The following is a description of a gene set: Pain in muscle. Myalgia Human Gene Set: HP_MYALGIA species: Homo sapiens, and this is the list of marker genes: PMP22, HLA-DPA1, SCN4A, MTTP, ALMS1, COX6B1, TNFRSF1A, NLRP3, MLX, IL12A, CTNNB1, ANK1, DSE, LRP12, DMD, TBX1, POLG2, MT-TK, LMNA, HLA-DRB1, ACP5, SLC25A4, SCN9A, LBR, APC, P4HA2, DNM1L, POLG, OBSCN, NOD2, DNM2, GPR101, IL2RB, TET2, HNRNPA1, RREB1 (NCBI Gene Id 6239), ANKRD55, NLRP12, ANO5, FKTN, POMT1, SDHA, MTMR14, ACADM, HLA-DPB1, LPIN1, PRDM5, TRAPPC11, PHKG1, CLCN1, RNASEH1, MOCOS, VCP, TWNK, ALDOA, MPV17, FKRP, TMEM126B, MATR3, BIN1, PDGFRA, DGUOK, GK, STAT4, SPTB, MT-CO1, CD247, HLA-B, PHKA1, HADHA, PGAM2, IL12B, IFNGR1, MRPS2, IL23R, JMJD1C, COMT, TK2, PTPN22, PTPN6, CHCHD10, UBAC2, LDHA, PHKB, NLRC4, GP1BB, CR2, SPTA1, DNA2, IL12A-AS1, PLAAT3, DNAL4, RYR1, EPB42 (NCBI Gene Id 2038), DNASE1L3, MSTO1, PTPN2, SLC4A1, ORAI1, ENO3, CAPN3, TLR4, ATP2A1, PHKG2, FAS, IL10, SLC12A3, RAD51, FILIP1, ERAP1, PPARG, MEFV, MIEF2, PNPLA2, ADA2, FDX2, STIM1, IL2RA (NCBI Gene Id 3559), CAV3, PHKA2, KIT, OPA1, SVIL, FLNC, PFKM, CRPPA, EXT2, CLCNKB, TPM2, KLRC4, MLIP (muscular LMNA interacting protein), ASXL1 (NCBI Gene Id 23393), GLA, BVES, ZNF469, KY, UFD1, PRTN3, RRM2B, OTULIN, HADHB, ACAD9, DYSF, TNXB, DNAJB6, ARVCF, FMR1, NTN1, HPDL, MYOT, LPIN2, CASQ1, AMPD3, MDM4, PYGM, POLR3A, HSPG2, MT-CO3, SEC24C, RBCK1, C4A, IRF4, DCC, AIP, HIRA, ALDH4A1, VWA1, HMGCR, PRORP, MVK, CPT2, CCDC78, AMPD1, CTLA4, MYF6, TRIM32, CNBP, PGK1, SLC25A42, SH3TC2, CAVIN1, IGHG2, CCR1, MT-TE, MYH7, ACADVL (acyl-CoA dehydrogenase very long chain), IGKC, LMNB1, EXT1, SRSF2